Given this list of marker genes Wnk3, Pck1, Mir99a, Fbp1, Xrcc6, Rac1, Efhd1, Mir137, Mir451a, Sst, Rcsd1, Stk39, Mir30b, Mir9-2, Hnmt, Mir7b, Slc12a2, Mir29b-2, Akr1b1, Pkn1, Mir9-1, Ybx3, Mir204, Aqp1, Letm1, Mir434, Trpv4, Oxsr1, Mir9-3, Micu1 (mitochondrial calcium uptake 1), Pdpk1, Epo, Slc2a1, Mir29c, Wnk1, Xrcc5, Mir100, Slc25a23, Ninj1, Mir29b-1, Abcb1a, here is a description of the gene set: Mouse Gene Set: GOBP_HYPEROSMOTIC_RESPONSE species: Mus musculus Any process that results in a change in state or activity of a cell or an organism (in terms of movement, secretion, enzyme production, gene expression, etc.) as a result of detection of, or exposure to, a hyperosmotic environment, i.e. an environment with a higher concentration of solutes than the organism or cell.